The following is a description of a gene set: Human Gene Set: WP_ACETAMINOPHEN_IN_ANALGESIA_AND_ANTIPYRESIS Acetaminophen in analgesia and antipyresis species: Homo sapiens, and this is the list of marker genes: KCNQ3, PTGS2, HTR1A, FAAH, KCNQ2, CACNA1H, TRPA1, PTGS1, TRPV1 (transient receptor potential cation channel subfamily V member 1)